The following is a description of a gene set: Mouse Gene Set: GOCC_WEIBEL_PALADE_BODY species: Mus musculus A large, elongated, rod-shaped secretory granule characteristic of vascular endothelial cells that contain a number of structurally and functionally distinct proteins, of which the best characterized are von Willebrand factor (VWF) and P-selectin. Weibel-Palade bodies are formed from the trans-Golgi network in a process that depends on VWF, which is densely packed in a highly organized manner, and on coat proteins that remain associated with the granules. Upon cell stimulation, regulated exocytosis releases the contained proteins to the cell surface, where they act in the recruitment of platelets and leukocytes and in inflammatory and vasoactive responses., and this is the list of marker genes: Cracr2a, Ece1, Rab27a, Unc13d (unc-13 homolog D), Vwf, Edn1